The following is a description of a gene set: The chemical reactions and pathways resulting in the breakdown of any hormone, naturally occurring substances secreted by specialized cells that affects the metabolism or behavior of other cells possessing functional receptors for the hormone. studied in species Mus musculus Mouse Gene Set: GOBP_HORMONE_CATABOLIC_PROCESS, and this is the list of marker genes: Ece1, Cyp19a1, Hsd17b11, Ugt1a7c, Cpa4, Dio2, Ide, Srd5a1, Ace, Spp1, Mme, Akr1c18, Sult1e1, Dio3